Given this list of marker genes HMGXB4, ACOX3, BRINP1, SREK1, CADM2, EMILIN1, RAB33B, LHX2, GSPT1, MAP4K5 (NCBI Gene Id 11183), HOXA9, VTI1A, ADGRL3, GPR180 (G protein-coupled receptor 180), PLA2G12B, CHIC1, SLC48A1, ENPP2, ANKRD17, RBM15, PPARGC1B, ZNF606, SAMM50, MPST, CREBBP (CREB binding protein), VASP, ATP8B2, ARHGEF33, GRIA1, BLTP3A, SDHD (NCBI Gene Id 91899), IGFBP5 (NCBI Gene Id 3488), here is a description of the gene set: Human Gene Set: MIR1238_3P Genes predicted to be targets of miRBase v22 microRNA hsa-miR-1238-3p in miRDB v6.0 with MirTarget v4 prediction scores > 80 (high confidence targets). from publication Chen Y, Wang X (PMID 31504780) species: Homo sapiens